The following is a description of a gene set: GABA is metabolized in the mitochondrial matrix to succinate by the serial action of two enzymes, 4-aminobutyrate aminotransferase and suucinate semialdehyde dehydrogenase. Failure of the second reaction is associated with a rare human genetic disorder. part of: GABA synthesis, release, reuptake and degradation studied in species Homo sapiens Reactome Pathway: Degradation of GABA, and this is the list of marker genes: ABAT, ALDH5A1